Given this list of marker genes Appl2, Stx1b, Appl1, Actn4, Cln3, Axl, Ppt1, Cav1, Nr1h2, Tsc2, Cdc42, Prom2, Nr1h3 (nuclear receptor subfamily 1, group H, member 3), Ankfy1, here is a description of the gene set: Any process that modulates the frequency, rate or extent of pinocytosis. Pinocytosis is the process in which cells take in liquid material from their external environment; literally 'cell drinking'. Liquid is enclosed in vesicles, formed by invagination of the plasma membrane. These vesicles then move into the cell and pass their contents to endosomes. studied in species Mus musculus Mouse Gene Set: GOBP_REGULATION_OF_PINOCYTOSIS